Given this list of marker genes SMAD1 (NCBI Gene Id 4086, SMAD family member 1), TGFBR1, ACVR1B, SMAD9, SMAD5, ACVR2B, MSTN, SMAD4, here is a description of the gene set: Myostatin signaling pathway. Pathway ID: N01457. Pathway type: Reference. Pathway class: nt06507 TGFB signaling. Pathway Definition from KEGG: MSTN -> (ACVR2B+(ACVR1B,TGFBR1)) -> (SMAD1,SMAD5,SMAD9) == SMAD4 Human Gene Set: KEGG_MEDICUS_REFERENCE_MYOSTATIN_SIGNALING_PATHWAY studied in species Homo sapiens